The following is a description of a gene set: from publication Motenko H, Neuhauser SB, O'Keefe M, Richardson JE (PMID 26092688) studied in species Mus musculus Mouse genes annotated to decreased liver tumor incidence (MP:0010266) retrieved from the Mouse Genome Informatics database via MouseMine Mouse Gene Set: MP_DECREASED_LIVER_TUMOR_INCIDENCE, and this is the list of marker genes: Tlr2, Foxm1, Mtdh, Myd88, Tert